Given this list of marker genes Bmp4, Tgfb1, Tgfb2, Wnt3a, Tbx5, Gper1, Kat2a, Dhx36, Mef2c, Myocd, Nrg1, Arrb2, Nkx2-5, Gsk3b, Efnb2, here is a description of the gene set: studied in species Mus musculus Mouse Gene Set: GOBP_POSITIVE_REGULATION_OF_CARDIOCYTE_DIFFERENTIATION Any process that activates or increases the frequency, rate or extent of cardiocyte differentiation.